Given this list of marker genes Fuom, Slc35c1, Slc2a1, Fcsk, Fpgt, here is a description of the gene set: studied in species Mus musculus The formation of GDP-L-fucose from L-fucose, without de novo synthesis. L-fucose is phosphorylated by fucokinase and then converted by fucose-1-phosphate guanylyltransferase (EC:2.7.7.30). Mouse Gene Set: GOBP_GDP_L_FUCOSE_SALVAGE